The following is a description of a gene set: studied in species Mus musculus Combining with a low-density lipoprotein particle and delivering the low-density lipoprotein particle into the cell via endocytosis. Mouse Gene Set: GOMF_LOW_DENSITY_LIPOPROTEIN_PARTICLE_RECEPTOR_ACTIVITY, and this is the list of marker genes: Stab1, Lrp10, Olr1, Stab2, Cxcl16, Lrp6, Ldlr, Lrp8, Lrp1b, Cd36